The following is a description of a gene set: Any process that modulates the frequency, rate or extent of the phosphorylation of peptidyl-tyrosine. Mouse Gene Set: GOBP_REGULATION_OF_PEPTIDYL_TYROSINE_PHOSPHORYLATION species: Mus musculus, and this is the list of marker genes: Hes1, Ptprc, Areg, Cck, Zzef1, Musk, Kitl, Hbegf, Crlf1, Clcf1, Itgb2, Ggnbp2, Errfi1, Pdgfrb, Ptger4, Itgb1, Cd80, Ptprz1, Tspan9, Pecam1, Yes1, Angpt1, Samsn1, Prkce, Arhgef2, Zfyve28, Tnfrsf14, Hnf4a, Ifng, Igf1, Pdgfa, Il12a, Hsf1, Il23a, Cntf, Fgfr3, Erbb4, Neurl1a, Psen1, Wnt3a, Inpp5f, Osbp, Acvr1, Lilrb4b, Il4, Ptpn11, Cd3e (CD3 antigen, epsilon polypeptide), Prkca, Ptpn1, Chmp6, Cntn1, Ehd4, Il22, Ppp2r5b, Lif, Epha7, Traf3ip1, Kit, Cav1, Cd74, Sh2d1b2, Hrg, Il34, Il6ra, Pdgfd, Lonp1, Il24, Sfrp1 (secreted frizzled-related protein 1), Ccl5, Tmem102, Adnp, Egf, Nox4, Syk, App, Lilrb4a, Enpp2, Lep, Il6st, Adam17, Hpx, Mif, Nedd9, Abi3, Hyal2, Il5, Il12b, Arrb2, Lrrk1, Ins2, Cass4, Ctnnd1, Il13, Fgf10, Lck, Angpt4, Plpp3, Socs3, Csf1r, Rictor, Unc119, Tsg101, Thbs4, Tnfrsf1a, Prnp, Socs1, Vegfb, Egfr, Il3, Adipoq, Pdcl3, Arl2bp, Zgpat, Psen2, Clec7a, Dvl2, Tnk2, Srcin1, Prkcz, Gata1, Osm, Cd4, Il15, Efna1, Parp14, Pdgfra (NCBI Gene Id 231312), Cd24a, Ncl, Hes5, Socs4, Bst1, Hax1, Mvp, Ifnar1, Il9, Sfrp2, Il22ra2, Tgfb1, Hcls1 (NCBI Gene Id 15163), Nrg1, Cd44, Trem2, Rasa1, Cspg4, Ptpn2, Ctf1, Il2, Abi2, Il9r, Pdgfc, Epo, Fgf7, Isl1, Spink1, Aplp2, Irf1, Il18, Gprc5b, Il21, Socs5, Jak2, Suz12 (NCBI Gene Id 74815), Rap2b, Lilra5 (leukocyte immunoglobulin-like receptor, subfamily A (with TM domain), member 5), Bmp6, Vegfa, Pdgfb, Cblc, Ripk2, Hdac2, Mtor, Mlst8, Ighm, Pak2, Itga5, Tnfsf18, Reln, Fcer1a, Dusp22, Csf2, Cav2, Lrp4, Ptpn6, Il6, Fyn, Il7, Iqgap1 (IQ motif containing GTPase activating protein 1), Nod2, Tnfrsf18, Il31ra, Dmtn, Vtn, Gdnf, Rap2c (RAP2C, member of RAS oncogene family), Nf2, Csf3, Itgb3, Ptk6, Pibf1, Ntf3, Sh2d1b1, Gprc5a, Agt, Il11, Bank1, Grem1, Dok7, Efna5, Src, Cadm4, Htr2a, Ptpn22, Abi1, Itgb2l, Tlr4, Cnot7, Vps25, Gfra1, Tnf, Agrn, Parp9, Fbxw7, Icam1, Cd40, Zfp592, Dgkq, Abl1, Fgf8, Tgfa